Given this list of marker genes Mesp2 (NCBI Gene Id 269949), Lin28a, Gm25296, Ass1, Lfng, Gm2824, Zfp362, Slc9a1, Gm15322, Zfp976, Zfp365, Glul, Cdc40, Hexim2, Flacc1, Ncor2, Abtb3, Kdm3a (NCBI Gene Id 73570), Cdh10, 1700008O03Rik, Tox2, Nynrin, Fut10, Ctbp2, Klhl34, Tsen34, Kdm4a, Zcchc24, Ddx56, Snx17, Pcbp4, Cul2, Zfhx4 (NCBI Gene Id 80892), Dis3l, Fam110d, Sptbn5, Pde7b, Tbl1xr1, Capg, Prtg, Aoc1l3, Fgfr2, 2010310C07Rik, Mrc1, Egflam, Limd1, Eml2, Arhgap18, Dusp6, Cdh20, Bcar3, Rbm19, Slc6a16, Aplnr, Gm9530, Impdh2, Gm19426, Acvr1, Cep295nl, Mir7b, Upp2, Lhx1, Slc13a4, Eif2b4, Edrf1, 5330413P13Rik, Tmem119, Zfp408, Pip4p2, 6430548M08Rik, Urgcp, Sp5, Foxh1, Tssk6, Mcf2, Rpl31-ps20, Dhx32, Gse1, Dusp7, Tnrc18, 2900052L18Rik, Inava, Stra6, C030047K22Rik, Slc37a2, Rack1, Sulf1, 5830418P13Rik (NCBI Gene Id 100529079), Zkscan5, Arid3a, 1700023G09Rik, H2bc27, Gm33280, 9030622O22Rik, Limch1, Samd4, Has2, Mfap4, E030030I06Rik (NCBI Gene Id 319887), Dll3 (NCBI Gene Id 233031), Pcdhgc4, Selenbp2, Psmd8, Acp6, Tpi1, Adgra2, Alkbh7, Ppp6r3, Arl14ep, Plekha6, Wasf1, Tyro3, Prp2rt, Gm15458, Cer1, Gm16876, Med6 (NCBI Gene Id 69792), BB218582, Fzd2, Fbxo11, Mtcl1, Fbxo36, Gm28876, Cnmd, Tmem198b, Frzb, Rbpms, Coasy, Fam117a, Cmc1, Gata3, Gatad2b, Rab11fip1, Evi5l, Pym1, Evx1os, Gm13259, Shb, Nono, Mir5122 (NCBI Gene Id 100628620), Cpsf4l, Car14, Ccnd2, 9430024E24Rik, Gm11587, Ppm1k, Ccdc8, Btla, Cdhr1, Rcor1, Cast, Kif13a, Arhgef10l, Hif1an, Gm28511, Map2k6, Mboat7, Il17b, Defb10, Trip12, Arhgap1, Adamts17, Chd7, Tsku, Zfp946, Grm2, Pou2f1, Bcl11a, Rbfox2, B530045E10Rik, Nol6, Rgs12, Gm10830, Smarcd3, Rasgrp3, Gm14051, Mir8114, here is a description of the gene set: Mouse Gene Set: LHX1_TARGET_GENES from publication Yevshin I, Sharipov R, Kolmykov S, Kondrakhin Y, Kolpakov F (PMID 30445619) studied in species Mus musculus Genes containing one or more binding sites for (Lhx1) in their promoter regions (TSS -1000,+100 bp) as identified by GTRD version 20.06 ChIP-seq harmonization.